The following is a description of a gene set: species: Homo sapiens from publication Gavish A, Tyler M, Greenwald AC, Hoefflin R, Simkin D, Tschernichovsky R, Galili Darnell N, Somech E, Barbolin C, Antman T, Kovarsky D, Barrett T, Gonzalez Castro LN, Halder D, Chanoch-Myers R, Laffy J, Mints M, Wider A, Tal R, Spitzer A, Hara T, Raitses-Gurevich M, Stossel C, Golan T, Tirosh A, Suvà ML, Puram SV, Tirosh I (PMID 37258682) Human Gene Set: GAVISH_3CA_MALIGNANT_METAPROGRAM_11_TRANSLATION_INITIATION In this study, an extensive analysis was conducted to define meta-programs (MPs) capturing intra-tumor heterogeneity across a spectrum of tumor types. The approach utilized non-negative matrix factorization (NMF) to analyze each cell type separately within individual tumor samples. This involved the analysis of malignant cells, macrophages, fibroblasts, endothelial cells, epithelial cells, T-cells, and B-cells. NMF was executed with varying parameter values (K=4, 5, 6, 7, 8, 9), thereby generating 39 programs for each cell type per sample. Each NMF program was summarized by the top genes based on NMF coefficients.\nRobust MPs were then delineated for each cell type using a set of stringent criteria, including recurrence within the same tumor, similarity to programs in other tumors, and non-redundancy within a tumor. Subsequently, these robust NMF programs were clustered (per cell type) based on Jaccard similarity, leading to the identification of MPs associated with each cell type.\nTo enhance the quality of the MPs, a refinement steps were undertaken, involving the removal of MPs suspected of reflecting low-quality data (with an overrepresentation of ribosomal proteins or mitochondrial-encoded genes), single-study inclusion, or similarity to miss-annotated cell types. Genes upregulated in subsets of cells of a given type within various tumors, and this is the list of marker genes: MRPL10, SNHG19 (small nucleolar RNA host gene 19), LTA4H, RPL22L1, LETMD1, CCNB1IP1, EIF3D, PAICS, SNHG8, EIF3E, CCDC85B, HSD17B11, ZNF581, APEX1, EPB41L4A-AS1, LYRM4, NME1 (NCBI Gene Id 7794), OXA1L, MYC, NBEAL1, PPP1R14B, RGS10, EIF2S3, ZNF277, H2AC25, C19orf48P, EIF4B, RSL1D1, EXOSC5, EIF3F, SNHG32, SLC27A5, SRM, NOA1, CFAP68, EIF3M, SNHG7, ZFAS1, MRPL45, EIF2A, IGBP1, AHCY, EPRS1, IMPDH2, ABHD14B, TKT, CCNG1, FBL, NOB1, TOP1MT